The following is a description of a gene set: studied in species Homo sapiens Pollakisuria Increased frequency of urination. Human Gene Set: HP_POLLAKISURIA, and this is the list of marker genes: BNC2, HOGA1, FMR1, DYSF, ALDH18A1, FA2H, NBN